The following is a description of a gene set: Tumorigenesis markers of head and neck squamous cell carcinoma (HNSCC): up-regulated in the 'early' tumors vs normal samples. studied in species Homo sapiens Head and neck squamous cell carcinoma (HNSCC) is the sixth most common cancer among men in the developed world. There is a need, for both clinical and scientific reasons, to find markers to identify patients with aggressive disease as early as possible, and to understand the events leading to malignant transformation and susceptibility to metastasis. We report the first large-scale gene expression analysis of a unique HNSCC location, the hypopharynx. Four normal and 34 tumour samples were analysed with 12 600 gene microarrays. Clusters of differentially expressed genes were identified in the chromosomal regions 3q27.3, 17q21.2-q21.31, 7q11.22-q22.1 and 11q13.1-q13.3, which, interestingly, have already been identified by comparative genomic hybridization (CGH) as major regions of gene amplification. We showed that six overexpressed genes (EIF4G1, DVL3, EPHB4, MCM7, BRMS1 and SART1) located in these regions are indeed amplified. We report genes that are highly differentially expressed between 'early' tumours and normal samples. Of these, we validated by quantitative PCR six novel poorly characterized genes. These genes are potential new markers of HNSCC. Comparing patients with relatively nonaggressive and aggressive tumours (without or with clinical evidence of metastasis 3 years after surgery), we identified 164 differentially expressed genes potentially involved in the acquisition of metastatic potential. This study contributes to the understanding of HNSCC, staging patients into prognostic groups and identifying high-risk patients who may benefit from more aggressive treatment. from publication Cromer A, Carles A, Millon R, Ganguli G, Chalmel F, Lemaire F, Young J, Dembélé D, Thibault C, Muller D, Poch O, Abecassis J, Wasylyk B (PMID 14676830) Human Gene Set: CROMER_TUMORIGENESIS_UP, and this is the list of marker genes: IL6, POSTN, FAP, PXDN, RBP1, LAMC2, CXCL8, PPFIA1, COL4A2, MFAP2, SPP1, NTS, PLAU, SMOX, FN1, IFI6, CHST2, COL3A1 (NCBI Gene Id 1281), SPARC, PTK7, LRRC15, COL1A2, LUM, NELL2, PLOD3, IL1B, APOBEC3B, MMP9, ACTN1, TNC, BMP1, SLC2A3, KRT17, THY1, MAGEA1, MMP1, MMP11, PFN2, TPTEP1, KRT16, G0S2, SERPINE1, UCHL1, MAGEA3, PDPN, COL5A2, CCL3, COL11A1 (NCBI Gene Id 317718), MYO1B, MMP12, MMP3, TNFAIP3, DEFB4A, LAMA3, ODC1 (ornithine decarboxylase 1), MMP10, CXCL1, OASL